Given this list of marker genes NNT, SSU72, DCLK2, CHMP5, AGO2, MYO9B, DNA2, ACP6, CHCHD10, ACP3 (acid phosphatase 3), B3GLCT (NCBI Gene Id 145173), DALRD3, GPR174, NBEAL2, IMMP2L, FOXK1, IRF4, GIT2, ECI2, LIFR, ELMOD2, BIRC2 (NCBI Gene Id 329), STIM2, TPD52, L1CAM, IMPACT (NCBI Gene Id 55364), SLC5A2, ING2, ILF2, MANBA, MIER1, MFAP5, PLK1 (polo like kinase 1), PTPN12, ANKH, KANSL2, C1orf52, MKRN2, GPATCH1, FAM120C, CLK3, ID2, SLC30A9, PLEKHA6, CMTM6, SLPI, LSM14B, KHNYN, FBXL4, BTBD1, IDH2, TFAM, RB1, ATP6AP1, TMEM86B, CCNE2, RSRC1 (NCBI Gene Id 51319), CERS4, ANKRD46, RAB24, OXR1, CRLF3, RGL1, RAB32, COG5, ZC3H12D, SMIM19, RREB1, ULK2, METAP1D, CENPO, FAM193B, ZC3H12A, ATG16L2, AP3B1, CCDC117, PTBP3, MARS2, DYRK1A, DAG1, CFAP68, MYH2, SBSN, IRF2BPL, CASP6, AKAP12, MID1IP1, HAUS3, HERC2, TOR1AIP1, EMILIN2, CLK4, RPH3AL, NUP214, G3BP2, SRSF6, PAQR8, TAPT1, TMOD3, PLA2G15, DDX3X, CTCF, FAAH, ANKRD11, NCBP2AS2, FLNB, PAXX, TSPYL4, ZCCHC24, TGIF2, RNF135, RELN, FEZ2, RNF6, NFKBIZ, TCAIM, ATP11C, RAB9A, CBX6, LIPC, METTL17, NCEH1, PHF3, LARP4B, GOSR2, UBR7, DHX15, ZNF652, FOXO1, GSE1, MAEA, TTLL3, CKLF, RRAS2, FAU, INO80D, POU2AF2, RAB8A, NLGN1, NRF1, DNAJB1, TRIM5, PRKCH, CCDC126, ARID4A, COX11, FAM118A, ATP2A3, MYO7A, NSMCE1, HNRNPA3, S1PR1, RPS6KA3, CSRNP2, CPEB4, PRKAB1, SLK, NUMA1, AFMID, FBRS, LMF1, PARP3, TENT5A, NRAS, UPP1, SPICE1, BMAL1, POLD1, CNOT2, RNF38, HLX (H2.0 like homeobox), RBMS1, RPL9 (ribosomal protein L9), CEP164, BRMS1, GNG2, FOXD2, SAPCD1, IDUA, SYVN1, C5orf34 (chromosome 5 open reading frame 34), LIMS4, LGALS1, HNRNPH1, NCOA2, HES6 (NCBI Gene Id 94875), RBM18, DUSP19, MRGPRE, PTPRCAP, PARP1, FICD, ZDHHC20, TRIOBP, CASP8, APPL2, ACRBP, UVSSA, PDK1, DDX20, here is a description of the gene set: Human Gene Set: GSE19888_ADENOSINE_A3R_INH_PRETREAT_AND_ACT_BY_A3R_VS_A3R_INH_AND_TCELL_MEMBRANES_ACT_MAST_CELL_DN Genes down-regulated in HMC-1 (mast leukemia) cells incubated with the peptide ALL1 followed by treatment with: Cl-IB-MECA versus T cell membranes. We demonstrate that the G protein Gi3 is the cellular target of the adenosine A3 receptor (A3R). By using a cell permeable peptide comprising the C-terminal end of Gαi3 fused to an importation sequence (ALL1) as a selective inhibitor of Gi3 signaling, we show that by coupling to Gi3, the A3R stimulates multiple signaling pathways in human mast cells, leading to upregulation of cytokines, chemokines and growth factors.Following contact with activated T cell membranes, endogenous adenosine binds to and activates the A3R, resulting in Gi3-mediated signaling. Specifically, the majority of ERK1/2 signaling initiated by contact with activated T cell membranes, is mediated by Gi3, giving rise to ALL1-inhibitable cellular responses. These results unveil the physiological GPCR that couples to Gi3 and establish the important role played by this G-protein in inflammatory conditions that involve adenosine-activated mast cells. We used microarrays to detail the effect of ALL1 on gene expression of HMC-1 cells activated directly by the A3 receptor, or by contact with activated T cell membranes. studied in species Homo sapiens from publication Baram D, Dekel O, Mekori YA, Sagi-Eisenberg R (PMID 20190146)